The following is a description of a gene set: Mouse Gene Set: GOBP_DORSAL_VENTRAL_NEURAL_TUBE_PATTERNING species: Mus musculus The process in which the neural tube is regionalized in the dorsoventral axis., and this is the list of marker genes: Tbc1d32, Foxa1, Wdr19, Gorab (NCBI Gene Id 98376), Gpr161, Mks1 (NCBI Gene Id 380718), Rab23, Cplane2, Traf3ip1, Prkaca, Psen2, Mnx1, Shh, Tmed2, Smo, Cdk20, Gsc, Pax7, Ift122, Sufu, Prkacb, Foxa2, Kif3a, Rnf220, Tulp3, Fkbp8 (NCBI Gene Id 14232), Gli3, Gas1, Ptch1, Tctn1, Psen1, Gli2, Wnt3a, Bmp4